Given this list of marker genes PLK2, RETSAT, ARL6IP5, SOCS5, ANGPTL2, AK3, TOMM70, BAMBI, FEM1C, ESD, GSK3B, MAPK1, GYPC, AK1, CSNK1A1, RBMS1, DUSP5, ABHD17B, IAH1, PIGL, PRICKLE2, NAE1, MINDY3, CDV3, MINK1 (misshapen like kinase 1), UBE2F, PPIL4, PSAT1, SLC41A2, DAGLB, TESK1, IL7, TMEM230, SLC35A1, GNAI3, ZNF706, COLGALT1, ATP11C, ARHGAP10, CLCN5, RNMT, TIMM10, LZTS2, CSRNP2, MYORG, ZNF697, PLEKHA3, ABCC5, RTKN (NCBI Gene Id 6242), MATK, ALG5, HSPA1A, SLC35B3, CKAP4, MAMLD1, DUSP11, GRAMD4, PLPP3 (NCBI Gene Id 8613), G6PC3, ZSWIM4, ST8SIA1, ESAM, PIP5K1C, PTGR3, F10, SLC48A1, CAB39L, BTC, TMEM181, PGRMC1, SEPTIN9, CLCF1, ITGB8, DCSTAMP, OLFM1, DMTF1, BCL6, ADRM1, PPARG, CCDC88A, CYBA, INTS15, TJP2, HMG20B, ANKRD55, EIF2B2, MET, ANKRD34A, PECAM1, CFAP418, SLC4A11, SMAD5, CNNM2, SLC37A4, AKAP8L, ZBTB21, TMC6, PTPN3, ABCF2, ARGLU1, ANXA1, FOSL2, CECR2, TANC2, ZPR1, CLYBL, IL3RA, C7orf25, CEBPG, ODR4, ATP6V1H, DPP8, VAMP4, ARHGAP5, MRPL43, STAP1, SLC12A5, PRKAB2, CLIC4, UBA6, TTI2, TGFBR3, NUDT19, KIF5B, S1PR4, DET1, SOST, PAFAH1B2, DPEP3, TSPAN17 (NCBI Gene Id 89852), SLC26A6, HDAC7, FEM1B, TMEM33, CAVIN1 (caveolae associated protein 1), SLC25A25, IKBKG, PTPRS, CSF2RB (NCBI Gene Id 3564), SPATA2, MXI1, FHIP2B, RASAL1, RGL1, UTP18, BNIP3L, TBC1D2B, XDH, ATF1, ZNF362, MMP9, NXF1, PITX1, NPRL3, KTN1, ASAP2, ARIH1, SMAD2, SOS2, TXNIP, GPX7, PTGES2, LETM1, BCL7B, ARHGEF12, HMGA1, BET1L, PPA2, LARP4B, ECPAS, PDE4DIP, PTGIS, LMBRD1, DLST, CHMP1B, GZMA, FTSJ3, ZC3H14, P2RY1, NCK1, PLEKHF1, LRRC28, ZCCHC2, STXBP6, ANXA4, GSKIP, MYRF, LSM14B, LTA4H, MICALL1, TRIP12, TMEM158, TFRC, CAPG, MRI1, ABCD2, FIBP, ALDH1A2, PDIA4, here is a description of the gene set: Genes down-regulated in bone marrow-derived macrophagesat 45 min stimulation of IL10 and LPS: wildtype versus IL6 knockout. Human Gene Set: GSE5589_WT_VS_IL6_KO_LPS_AND_IL10_STIM_MACROPHAGE_45MIN_DN IL-10 or IL-6 stimulation of control 129xC57BL/6 murine bone marrow derived macrophages in the presence of LPS. We used microarrays to detail the global programme of gene expression changes in response to IL-6 or IL-10 stimulation in the presence of lipopolysaccharide. BMDMs were isolated from control, IL-6-/-, and IL-10-/- mice on a 129XBL/6 mixed background mice and differentiated in the presence of CSF-1 for 6-7 days. Cells were scraped and plated in 6 well plates at 2x10e6/well. Cells were washed with complete DMEM and rested for 1-2 hr before stimulation with combinations of IL-10 (10 ng/ml), IL-6 (2 ng/ml) or LPS (100 ng/ml) for 45 min or 180 mins. Complete biological replicates were performed. species: Homo sapiens from publication El Kasmi KC, Holst J, Coffre M, Mielke L, de Pauw A, Lhocine N, Smith AM, Rutschman R, Kaushal D, Shen Y, Suda T, Donnelly RP, Myers MG Jr, Alexander W, Vignali DA, Watowich SS, Ernst M, Hilton DJ, Murray PJ (PMID 17114459)